Given this list of marker genes BMP2, ENGASE, CNTN1, MPRIP, FGF2, TGFB3, PAXBP1, SPN, POLR3G, SLC12A6, WFDC2, CD248, EREG, NRCAM, FGF5, SLC26A10P, ALMS1, KRT86 (NCBI Gene Id 650428), ADAM19, UBE2D2, ITGAM, FHL3, ELOVL5, MYL4, SIGLEC7, HGF, AQP6, NECTIN1, MAGEA9, PTCRA, SSX2IP, CNN1, CXCL3, MMP24, CEACAM1, TOX3, PDGFB, RPL12, EIF5, ANKRD2, RGS16, EXO5, CRABP2, VEGFA, here is a description of the gene set: species: Homo sapiens from publication Parent R, Kolippakkam D, Booth G, Beretta L (PMID 17483347) The mammalian target of rapamycin (mTOR) pathway, a major regulator of translation, is frequently activated in hepatocellular carcinomas. We investigated the effects of mTOR activation in the human HepaRG cells, which possess potent hepatocytic differentiation capability. Differentiation of HepaRG cells into functional and polarized hepatocyte-like cells correlated with a decrease in mTOR and Akt activities. Stable cell lines expressing an activated mutant of mTOR were generated. Sustained activation of mTOR impaired the hepatocytic differentiation capability of these cells as shown by impaired formation of bile canaliculi, absence of polarity, and reduced secretion of alpha1-antitrypsin. An inhibitor of mTOR, rapamycin, was able to revert this phenotype. Furthermore, increased mTOR activity in HepaRG cells resulted in their resistance to the antiproliferative effects of transforming growth factor-beta1. Profiling of polysome-bound transcripts indicated that activated mTOR specifically targeted genes posttranscriptionally regulated on hepatocytic differentiation. Three major biological networks targeted by activated mTOR were identified: (a) cell death associated with tumor necrosis factor superfamily members, IFNs and caspases; (b) lipid homeostasis associated with the transcription factors PPARalpha, PPARdelta, and retinoid X receptor beta; and (c) liver development associated with CCAAT/enhancer binding protein alpha and hepatic mitogens. In conclusion, increased mTOR activity conferred a preneoplastic phenotype to the HepaRG cells by altering the translation of genes vital for establishing normal hepatic energy homeostasis and moderating hepatocellular growth. Genes down-regulated in HepaRG cells (liver cancer) expressing constituvely active form of MTOR. Human Gene Set: PARENT_MTOR_SIGNALING_DN